The following is a description of a gene set: Human Gene Set: GSE14769_UNSTIM_VS_60MIN_LPS_BMDM_DN The innate immune system is a two-edged sword; it is absolutely required for host defense against infection, but if left uncontrolled can trigger a plethora of inflammatory diseases. Here we used systems biology approaches to predict and validate a gene regulatory network involving a dynamic interplay between the transcription factors NF-κB, C/EBPδ, and ATF3 that controls inflammatory responses. We mathematically modeled transcriptional regulation of Il6 and Cebpd genes and experimentally validated the prediction that the combination of an initiator (NF-κB), an amplifier (C/EBPδ) and an attenuator (ATF3) forms a regulatory circuit that discriminates between transient and persistent Toll-like receptor 4-induced signals. Our results suggest a mechanism that enables the innate immune system to detect the duration of infection and to respond appropriately. from publication Litvak V, Ramsey SA, Rust AG, Zak DE, Kennedy KA, Lampano AE, Nykter M, Shmulevich I, Aderem A (PMID 19270711) studied in species Homo sapiens Genes down-regulated in comparison of unstimulated macrophage cells versus macrophage cells stimulated with LPS (TLR4 agonist) for 60 min., and this is the list of marker genes: BTG2, FOXO1, IL10RA, TGIF1, NFKBID, ZNF81, MAP3K8, CCL7, ARHGEF2, WDR47, TNFAIP2, ID2, GDF15, CD69, SELE, ZFAND5, CXCL1, TMEM248 (transmembrane protein 248), CDK5R1, MAPKAPK2, JUN, DNAJB4, SLFN12L, BICRA, CEP350, CCRL2, TLE4, ID3, ATF3, CFLAR, RAPGEF1, BMP2, SOCS7, SPRYD7, B4GALT5 (beta-1,4-galactosyltransferase 5), KDM6B, NFKBIB, PIM1, SGMS1, ODC1, ANKRD33B, CCL4, ITPKC, ACSL3, BIRC3, CSRNP1, NRROS, MMP13 (matrix metallopeptidase 13), F3, WSB1, IER2, RNASE10 (ribonuclease A family member 10 (inactive)), FOS, RELB (NCBI Gene Id 5971), IRF1, CCL5, EHD1, CCDC40, FZD5, PLSCR4, TMEM39A, TLR2, EGR2, CLEC4E, MALT1, ARID5A (NCBI Gene Id 10865), OTUD1, FURIN (NCBI Gene Id 5123), CLDND1, ZMYM2, GADD45B, DUSP5, KLF6, GPR84, IFRD1, ETV3, UAP1, SLC38A2, CD83, NUPR1, FAM72A, PTGS2, VIM, ZNF654, SKIL, SRGN, IRGQ, CCDC71L, DNAJA2, FAM133B, IL1B, P2RY2, ERRFI1, CDKN2B, GJA1, BCL10, PICALM, CEBPB, CDC42EP2, ZFP36L1, DDX5, SPRY2, HILPDA, RASGEF1B, MARCKSL1, CCL13, CDK17, SLC25A25, USP16, IL10, RIPK2, HLA-G, LIMA1 (NCBI Gene Id 51474), IER5, RNF103, TOB1, STIL, RBM39, TNS3, TIPARP, RNF19B, TRIM13, RABGEF1, MAPK8, SDE2 (SDE2 telomere maintenance homolog), PLK2, ETF1, PLEK, PHLDA1, ATL2, MXD1, NCDN, HERPUD1, FEM1C, OSM, DHX15, DUSP2, REL, TNFSF9, VPS37C, HMGB2, PNRC1, DUSP4, ICAM1, SOD2, SIAH2, CITED2, PLSCR1, DUSP16, KCTD12, ZC3H13, FRMD4A, HIF1A, GEM, HLA-B, NOCT, ZC3H12C, IER3, PLAUR, NUAK2, GTF2B, TMCC1, ZNF800, FOSL2, FABP4, HNRNPLL, MTMR12, SLAMF7, STK35, SGK1, CD14 (NCBI Gene Id 929), C9orf72, BCL2A1, SQSTM1, FRMD6, ACOD1, STX11, INTS13, MCL1, MTMR14, SOWAHC, HSPA1A, DUSP1, NDEL1, MAN1C1, MEX3C, ABHD17C, BCL2L11, KLF7, ZC3H12A (NCBI Gene Id 80149), RYBP, HSPA1B, CCNL1, MYC, TASL, PTCH1, NFKBIE, RAB20, TAF7, NRIP1